Given this list of marker genes GMPR, ADA, DCK, PNP (purine nucleoside phosphorylase), DGUOK, GMPR2, AMPD1, AMPD2, HPRT1, ADK, MAPDA, APRT, AMPD3, here is a description of the gene set: Human Gene Set: REACTOME_PURINE_SALVAGE Purine salvage species: Homo sapiens